The following is a description of a gene set: Human Gene Set: HE_LIM_SUN_FETAL_LUNG_C7_TM4SF4_POS_CHODL_POS_NEURON_CELL studied in species Homo sapiens TM4SF4+ CHODL+ neuron from publication He P, Lim K, Sun D, Pett JP, Jeng Q, Polanski K, Dong Z, Bolt L, Richardson L, Mamanova L, Dabrowska M, Wilbrey-Clark A, Madissoon E, Tuong ZK, Dann E, Suo C, Goh I, Yoshida M, Nikolić MZ, Janes SM, He X, Barker RA, Teichmann SA, Marioni JC, Meyer KB, Rawlins EL (PMID 36493756), and this is the list of marker genes: NXPH4, SLC5A7, MYT1, RPS6KL1, IGLON5, ST7, HMX2, SYNPO2, AKAP6 (A-kinase anchoring protein 6), CLCN4, ATRNL1, VSTM2A, HS3ST5, NDUFA4L2, CXADR, MAB21L2, ARID3B, POU2F2, EPS8L1, SNX10, STX1A, FBP1, SGIP1, ARHGEF28, BTBD8, CNGB1, CNTNAP2, GPR22, TLE6, APC2, TSHZ3, NRSN1, ST6GAL2, CDK5R1, CPT1C, FNDC5, TRIM36, TAC3, MTMR7, IGFBPL1, CHODL, PPP1R1A, PLEKHA6, PHYHIPL (phytanoyl-CoA 2-hydroxylase interacting protein like), TM4SF4, NYAP2, CDK5R2, ARHGEF3, REM2, ABCB1, OLFM3, YPEL4, HID1